Given this list of marker genes RNU4ATAC, PLAGL1, VARS1, SLC25A19, EBP, MYCN, NFASC, ORC1, ATR, HYMAI, here is a description of the gene set: Human Gene Set: HP_SMALL_ANTERIOR_FONTANELLE Small anterior fontanelle Abnormally decreased size of the anterior fontanelle with respect to age-dependent norms. species: Homo sapiens